The following is a description of a gene set: This event has been computationally inferred from an event that has been demonstrated in another species.<p>The inference is based on the homology mapping from PANTHER. Briefly, reactions for which all involved PhysicalEntities (in input, output and catalyst) have a mapped orthologue/paralogue (for complexes at least 75% of components must have a mapping) are inferred to the other species. part of: Generic Transcription Pathway Reactome Pathway: Transcriptional regulation by RUNX3 electronically inferred by orthology from the curated human pathway species: Mus musculus, and this is the list of marker genes: Psmd12, Psmb5, Psma2, Smurf1, Psmd6, Snw1, Psma5, Psma6, Psmc6, Trp53, Yap1, Ubb, Psma1, Psmb7, Psmb6, Psma4, Hdac4, Psma7, Psmd13, Ccnd1, Cbfb, Psma3, Smad3, Psmd7, Tead4, Psmc1, Psmc2, Tcf7l2, Psmc3, Rps27a, Tgfb1, Psmc4, Ctnnb1, Psmc5, Tcf7, Ep300, Smurf2, Psmd1, Psmb4, Tcf7l1, Tead2